The following is a description of a gene set: Genes predicted to be targets of miRBase v22 microRNA mmu_miR_880_3p in miRDB v6.0 with MirTarget v4 prediction scores > 80 (high confidence targets). from publication Chen Y, Wang X (PMID 31504780) studied in species Mus musculus Mouse Gene Set: MIR_880_3P, and this is the list of marker genes: Uap1, Jarid2 (NCBI Gene Id 97879), Zfp827, Fmr1, Phlpp2, Atrn, Pramel24, Csgalnact2, Slc9a9, Kcnd2, Pramel5, Eif4ebp3, Ppargc1a (NCBI Gene Id 320239), Rdh10, Rnf139, Impg2 (NCBI Gene Id 224224), Zfp445, Igfbp5, Bbs2, Meis2, Exph5, Map3k7, Map2, Zic3, Usp1, Lamb1, Kdm3b, Tcf12, Slc23a2, Fmo1, Fbxl7, Raph1, Cd200l1, Ccdc14, Epc2 (enhancer of polycomb homolog 2), Fasl, Cntn1, Prob1, Cdadc1, Lrig3, Dis3, Mbd5, Stox2, Mllt11, Or2ag2b